Given this list of marker genes FAM117A, NTRK3, IPO4, NRIP2, CPEB4, BCL3, RAP2C, CSF1R, MT2A (NCBI Gene Id 4502), BCL6B, LTB, WNT10A, IL6 (NCBI Gene Id 3569), SMPD3, FHL3, ZFAND3, UBE2H, SLC25A18, TCEA2, SLC12A2, KAT7, ENKD1, TNFSF15, BATF, ARID1A, MYADM, RELB, ALG6, GPR182, CD86, SH3KBP1, FGF1, CCND2, POU2F3, NFKB2, ETV1, SH2B3, CSF2RB, CNTNAP1, BIRC3, PTGES, LASP1, GDPD5, KY, TFEC, TUBA1A, HOXA4, SLC6A12 (solute carrier family 6 member 12), MAML2, C1QL1, UBD, PNKD, SLC44A1, PCSK2, CREB1, TNIP1, NRGN, NR2F2, RPS6KA4, ENO3, BNC2, TP53 (tumor protein p53), UPF2 (NCBI Gene Id 26019), MSX1, FOXS1, BMP2K, PLXNB1, TNKS1BP1, PFN1, JAK3, PPP2R5E, TLX1, CHD6, G3BP1, MIDEAS (NCBI Gene Id 91748), SOX5, CD70, CDC27, WRAP53, KCNS3, CNIH2, GATA4, ENTHD1, IL1RN, HSPG2, LPO, REL, CCDC80, TNFRSF1B, ZNF532, IL1RAPL1, PKN1, FTHL17 (ferritin heavy chain like 17), CD74, N4BP1, CCL5, SLAMF8, PRR34, UBE2M, CCR10, ORAI1, LIX1L, E2F3, IL2, NFAT5, STX4, LAMA1, MADCAM1, IER5, STAT6, PSME3IP1, CALCOCO1, RASSF2, TOM1L1, CXCR5, FUT7, CCDC107, TRIM47, TPM3, RSPRY1, TNFRSF9, CNTF, CYLD, GREM1, EHD1, RYBP, GEM, DCLK1, SP6, MSC, RBMS1, HIVEP1, S1PR2, NFKBIA, here is a description of the gene set: Comprehensive identification of all functional elements encoded in the human genome is a fundamental need in biomedical research. Here, we present a comparative analysis of the human, mouse, rat and dog genomes to create a systematic catalogue of common regulatory motifs in promoters and 3' untranslated regions (3' UTRs). The promoter analysis yields 174 candidate motifs, including most previously known transcription-factor binding sites and 105 new motifs. The 3'-UTR analysis yields 106 motifs likely to be involved in post-transcriptional regulation. Nearly one-half are associated with microRNAs (miRNAs), leading to the discovery of many new miRNA genes and their likely target genes. Our results suggest that previous estimates of the number of human miRNA genes were low, and that miRNAs regulate at least 20% of human genes. The overall results provide a systematic view of gene regulation in the human, which will be refined as additional mammalian genomes become available. Genes having at least one occurrence of the highly conserved motif M86 GGGNNTTTCC in the regions spanning 4 kb centered on their transcription starting sites. This matches the transcription factor binding site V$NFKB_Q6_01 (v7.4 TRANSFAC). from publication Xie X, Lu J, Kulbokas EJ, Golub TR, Mootha V, Lindblad-Toh K, Lander ES, Kellis M (PMID 15735639) species: Homo sapiens Human Gene Set: GGGNNTTTCC_NFKB_Q6_01